Given this list of marker genes EPM2A, ATP6V0A1, KIF1C, ARX, NHLRC1, here is a description of the gene set: A type of myoclonus in which the myoclonias shift from body region to another in a random and asynchronous fashion. Erratic myoclonus can affect the face or limbs, are brief, single or repetitive, very frequent and nearly continuous. studied in species Homo sapiens Erratic myoclonus Human Gene Set: HP_ERRATIC_MYOCLONUS